The following is a description of a gene set: species: Homo sapiens Human Gene Set: HP_FUNCTIONAL_ABNORMALITY_OF_THE_INNER_EAR Functional abnormality of the inner ear An abnormality of the function of the inner ear., and this is the list of marker genes: OTX2, MAK, BCS1L, STAT4, ERCC6 (NCBI Gene Id 282965), RFT1, LRP5, CDHR1, REST, PNPLA6, NLRP12, COG7, MT-ND4, GRXCR2, MITF, SLC9A1, EDC3, EDN3, MT-CYB, SCN2A, CDC42BPB, ADA2, SLC30A9, HOXA11, SQSTM1, WBP4 (WW domain binding protein 4), KCNAB2, COL4A3, ARSL (NCBI Gene Id 415), CNOT3, RAD21, SIX1 (SIX homeobox 1), SMC3, CALM2, PCARE, PTRH2, CNNM2, IL12A-AS1, SCN1B, SIX3, CRYM, FTO, IDH3B, GSDME, PGAP2, S1PR2, OTOGL, TRDN, FOXRED1, CALM1, ARSG, ALMS1, GABRD (NCBI Gene Id 2563), ARNT2, GJA8, DHDDS, PRPF6, DNAJC19, RFC2 (NCBI Gene Id 5982), MT-ND2, FGF10, C4A (complement C4A (Chido/Rodgers blood group)), IL12A, GUCA1B, ARID1B, MARS2, NDUFAF8, ASCL1, COL25A1, IL12B, IGF1, GJB3, PRPF4, FHL2, XPC, HLA-DPB1, HLA-B, RARA, PTPN22, ATP1A3, PEX10, COA8, CDON, ATP5F1D, NR2E3, GIPC3, RBM8A, CRIPTO, PEX14, NEU1 (neuraminidase 1), MAP3K20, ODC1, NDUFV2, NDE1, DNMT1, ARX, TMEM126B, IDUA, COQ6, CPLX1, TTN, SLC39A7, ACVR1, CYP7B1, RHO, FBXW4, DHX38, GMPPB, ALDH18A1, CEP78, OTOG, RNU12, RFC1, PRDM16, POLD3, DIAPH1, MT-TC, NPM1, PLAA, DSPP, EPRS1, SEM1, TYMP, BCAP31, KCNA5, NKX2-6, POLG, DCAF17, ATP5MK, TPM2, WDR37, POU3F4, FGF3, POMK, PRDM12, RYR1, LRP12, GLA, MYCN, WDR11, STAT5B, TAC3, MRAS, WDR81, BICRA, HOXA2, EBP, SNAP25, VEZF1, TRNT1, TGIF1, LDB3, PRDM5, LRP4, SH2B1, TAFAZZIN, IFT140, FKTN, MPL, VAMP1, BAG3, MRPS7 (NCBI Gene Id 64967), B3GALT6, SLC52A2, SLC17A8 (NCBI Gene Id 64944), BUD23, DBH, KIF7, PEX26, ABHD12, FOXP2, HAAO, BTRC, NEDD4L, CRYAB, MT-TK, RAC1, RIT1, HDAC4, CCR1, KLHL7, NDUFS4, TMEM147, PSEN2, MLX, TRAPPC11, CSRP3, ROBO3, ADK, BDP1, TSPEAR, CEACAM16, MAP2K1, SLC4A11 (solute carrier family 4 member 11), EBF3, TMTC4, NDUFB3, IGBP1, TRAPPC4, GCGR, HGF, CRLS1, PERP, ERCC3, CHCHD10, COX11, IL10, TRRAP, ASAH1, GLI2, TRPM4, KCNH1, HACE1, PMP22, GDF5, SOX6, DNASE1L3, IDS, CLRN2, PRPS1, LRAT, XPA, FH, MT-ND1, GLYCTK, SOS1, ELOVL1, NAA80, ZMPSTE24, NDUFAF5, KIZ, CFAP418, SLC25A4, MINAR2, RPE65, TMEM270, OTOF, SELENOI, TPO, MYH11, MEFV, JAG1, SLC29A3, NDUFAF1, DHX16, TPK1, GPR156, TULP1, ACOX1, PEX5, ABHD5, PJVK, PEX13, RILPL1, PHOX2A, ILDR1, DLL1 (delta like canonical Notch ligand 1), POGZ, SLC25A11, USH2A, TIMM8A, ELMOD3, TMPO, NCF1, AFF4, GATA6, RNF113A (NCBI Gene Id 7737), DIABLO, EP300, PDE6G, HTRA2, PISD, MYH14, PLCH1, EPAS1, TBL1XR1, HS2ST1, RLBP1, NDUFB9, MED12, ACY1, NDUFB11, PIK3R1, CTBP1, SARDH, TBC1D24, RPL10, RBP3, SCN2B, KITLG, SGPL1, NDP, CA4 (carbonic anhydrase 4), FGF17, CNOT1, ERBB2, PLN, COL13A1, GNAS, NSD2, SCN5A (NCBI Gene Id 652341), GJB2, METTL27, FGFR3, GAB1, CDC42, ATP6V1B2, DISP1 (NCBI Gene Id 84976), TAOK1, ITGB3, CLPP, VPS13B, PRKAR1A, ESRP1, NDUFAF2, CDC45, SNAI2, POLD1, MYO7A, MYH6, UQCC2, DSP, LRP2, COX16, PRKDC, GYG1, SDHA, NDUFA6, CALR, G6PC3, MRPS2, FUS, SBF2 (NCBI Gene Id 81846), ZNF699, PPIP5K2, TOPORS, MANF, COL9A3, VPS4A, IMPG1, RP1L1, COCH, DKK1, DNAJC3, TBK1, TRPV3, LORICRIN, MT-TN, CCDC141, PDE6B, WFS1, CAP2, LARS2, STAT3, SCAPER, CHD7, CASZ1, ATPAF2, NEXN, SCN4B, PLS1, CBL, VPS37D, KCNE1, DLST, GET3, CLCN3, CLDN9 (NCBI Gene Id 9080, claudin 9), SIX6, SCD5, MECOM, SMCHD1, DHCR7, ITGA2, PEX16, DMP1, TACR3, GNB1, SNAP29, CCDC50, CNGB1, P2RX2, COL4A5, AGRN, RNF13, DVL1, KCNN3, ABCD1, PRMT7, GAS1, SLC19A2, WAC, ACTG1, MCM2, NDRG1, AHR, SPTBN1, STXBP2, RRAS, MT-ATP6, TECRL, MT-TQ, GATA4, GLIS3, SPRY4, NAXD, GUCY2D, HGSNAT (NCBI Gene Id 8119), SLC1A3, DTYMK (NCBI Gene Id 9102), PORCN (porcupine O-acyltransferase, NCBI Gene Id 65017), PML, NDUFAF4, CRX, TIMMDC1, MARVELD2, TNNT2, TRPV4, SLC26A4, NDUFA11, TBL1Y, P4HA2, KCNJ10, KARS1, HAX1, MT-TI, PNP (purine nucleoside phosphorylase), NOTCH3, GJA5, ATP11A, VCP, RP2, SOST, KDM6A, SETD2, ABCC1, KIAA1549, MLXIPL, PSEN1, EPG5, ABCC9, SLC35A2, LZTR1, EYA1, BCOR, ANKH, SPATA7, SPTSSA, CNBP (NCBI Gene Id 7555), GTF2I, SLC18A3, UBA1, CHD2, DES, ACTB, MT-CO3, IDH3A, TP63, GIPC1, FITM2, FAM149B1, THPO, LETM1, DNMT3B, CREBBP, ARSA, HSD17B4, PTDSS1, OPA1, NIPBL, BSND, ATP6V0A4, DUX4, ARL6, GABRB3, CRKL, TLR4 (NCBI Gene Id 7099), RPGR, GPSM2, CRB1, TPRN, ZIC2, PDE1C, OFD1, PRRT2, NDUFS3 (NCBI Gene Id 4722), NDUFS8, NUP155, ZNF469, FGF8, NEK2, KIAA0586, FEZF1, GRXCR1, ALG12, CLIP2 (NCBI Gene Id 84805), ATP5F1A, MYO9A, ATG7, ERAL1, CARS1, CERKL, HLA-DPA1, FAM161A (NCBI Gene Id 84140), NCAPG2, GTF2H5, MT-TE, SNX14, AIFM1, ABCC6, MT-ND6, ROBO1, TBCK, AP1S1, PEX11B, SCN1A, TK2, MAPK10, VCL, GJA1, SH3TC2, NODAL (nodal growth differentiation factor), MYMK, ATXN3, MAP1B, FGFR2, MEN1, ERCC8, SALL4, IYD, NDUFB10, BAZ1B, IMPG2, ANOS1, SNRNP200, MIR96, ATP5F1E, ASH1L, PRPF31, ATP1A2, HS6ST1, NSMF, IARS2 (NCBI Gene Id 55699), KCNJ2, NABP1, CDK8 (NCBI Gene Id 1024), COL27A1, TUBB3, IRF2BP2, GNRHR, ELN, TNFRSF11B, MOGS, TARDBP, KCNA1, MICOS13, CDH11, KISS1R, KRAS, CLTC (clathrin heavy chain), FOXC1, SUCLA2, EFNB1, CCND1, ELMO2, BRAF, BMP4, SDHC, MT-CO1 (mitochondrially encoded cytochrome c oxidase I), MYO6, PDE6A, INF2, CTNNB1, RDH12, MTSS2, PRPF8, NDUFS7, USH1C, MYO3A, PRPF3, EPOR, FOXH1, PDGFB, MYH7, PCDH15, HOXB1, CDH23, SOS2, ARHGEF18, RNF170, PEX1 (NCBI Gene Id 7788), PPP2R3C, PDK3, SLITRK6, PTPN11, ATP2B2, TOP3A, BEAN1, TBX22, KCNJ5, RRAS2, AP1S2, BEST1, COL4A6, UBR1, IL23R, JUP, DNMT3A, PNPLA2, TMC1, COL9A2, RASA2, SDHAF2, FIBP (NCBI Gene Id 9158), MT-TF, EIF3F, CTLA4, TXNRD2, MRPS28, ACO2, FSCN2, TMEM126A, MPEG1, AIP (aryl hydrocarbon receptor interacting protein), GMPPA, SRPK3, DLX6, GRHL2, RNF220, AARS1, GLI3, TUBA1A, TBL2, CIB2, TG, NDUFAF3, MAN2B1, TMEM127, ZBTB16, MT-TH, MMP23B, VHL, YAP1, SOX2, ATP6AP1, CAT, MYBPC3, GPC4, MT-TL1, PROK2, KCNJ3 (potassium inwardly rectifying channel subfamily J member 3), LRTOMT, SETBP1, GBA2, FAT4, NDUFA1, POU1F1, SPRED2, GGPS1, PHEX, GTF2IRD1, DAB1, MPZ, SLC26A5, PIK3C2A, ATP6V1B1, MYD88, MBTPS2, HESX1, PIGV, JPH2, DNM1, DUSP6, CUX2, SGCD, MPZL2, KCNQ1, NAGA, ERCC5, DIAPH3, GDF6, ROM1, SERAC1, ARHGDIA, GALK1, NDUFS6, LIMK1, TP53, TRMT10C, KCNQ2, SPNS2, USP48, TAF6, SNUPN (NCBI Gene Id 10073), PEX2, RBMX, LMNB1, SH2B3, PHYH, NF1, TWNK, MECR, SRP72, CLCNKA, SMC1A, ESPN, TET2, DCHS1, NOP56, TNNC1, IARS1, FOXI1, TCAP, IFT88, SEMA4A, ENPP1, GTF2IRD2, ERCC4 (NCBI Gene Id 7509), SLC52A3 (solute carrier family 52 member 3), ARL3, NARS2, LMOD2, TARS1, NMNAT1, IFNGR1, TUBB4B, VPS33B (VPS33B late endosome and lysosome associated), BCKDK, FBN1, TPM1, MERTK, CD164, DLX5, DMXL2, GJB1, NDUFV1, SLC5A7, NOG, GJB6, SURF1, MT-ATP8, SYNE4, MT-TW, PCNA, SOX10, MARS1, JAK2, TFAP2A, VSX1, PRKCZ, COX10, SOX3, MVK, NPPA, NUMA1, KCNE2, ATRX, RRM2B, CLIC5, CNGA1 (cyclic nucleotide gated channel subunit alpha 1), PDZD7, NDUFS2, AFG2A, CACNA1A, FXN, CSPP1, HDAC8, NR0B1, MYL2, MPLKIP, CLDN14, PAX3, CACNB4, RRM1, PEX19, RYR2, SDHD (succinate dehydrogenase complex subunit D), COL3A1 (collagen type III alpha 1 chain), AP3D1, ALG11, PITX2, TTR, CC2D2A, FBXW7, PPCS, KLRC4, UBE4B, ERCC2, NKX2-1, KMT2D, UBAC2, EYS, MYO15A, COL11A2 (NCBI Gene Id 494120), SAG, ADAMTSL1, ZFX, ERAP1, RP1, PGM3, FKBP14, FAS, RECQL4, XRCC4, PRORP, TWIST1, SALL1, CDC14A, COL11A1, RAF1, GP1BA, DCDC2, MIA3, MET, PRG4, UNC13D, THRB, MT-ND3, RBM20, ESRRB, RET, AFG2B, MPDZ, CISD2, MAFB, TNNI3, ZNF513, PROP1 (NCBI Gene Id 5626), ACTN2, MT-TV (mitochondrially encoded tRNA-Val (GUN)), SLC12A3, DCC, RAB23, RTTN, SUFU, LUZP1, PEX12, ARL2BP, CASQ2, PHOX2B, FIG4, NLRP3, SPTBN4, FIP1L1, RPL3L, FLI1, SHH, RDX, CACNA1G, RP9, COG5, FKBP6, FLNA, GATA2, PSAP, VPS11, TUB, MT-ND5, LMX1B, CCBE1, SDHB, LONP1, CD109 (CD109 molecule), BRD4, CLCNKB, BBS2, BAG5 (NCBI Gene Id 9529), AP1B1, PTCH1, TAF1A, NEFL, NDUFS1, COQ2, PRCD, OTOA, RPS6KA3, PDGFRB, IMPDH1, POMGNT1 (NCBI Gene Id 55624), GATA5, SMPX, STX1A, C1QBP, MDH2, ANKRD1, MYL4, SPTLC1, NKX2-5, MAF, HSPG2, PEX6, ADPRS, CD151, GRAP, LARS1, SYT2, SPEN, SLC25A1, ALG2, MT-TP, PRF1, PCNT, STIL, KIF1B, ROR1, CHAT, LHX4, MT-CO2, CHN1, PAX2, AAAS, HOXA1, SLC12A2, WNT10B, PEX3, TMEM38B, FAM20C, IFT172, DUOXA2, CALM3, RNASET2, COG4, NEUROG1, ERCC1, GUSB, SLC39A14, KCNJ16, GATA3, RDH5, LOXHD1, RIPOR2, ZIC1, SUMF1, RERE, ADGRV1, TDO2, PUS7, AMMECR1, ITGA2B, BBS1, DNAJC30, CDK5RAP2, ZEB2, RPS28, MYH9, SEMA3A, TRIOBP, CEP250, CHSY1, MT-RNR1, GJC2 (NCBI Gene Id 57165), FRG1, PNPT1, REEP6, TTC8, GP1BB, EIF4H, IL17RD, DUX4L1 (NCBI Gene Id 22947), BTD, ADCY1, COL9A1, BTK, HAND2, FGF14, DDB2, USH1G (USH1 protein network component sans), CASK, ZNF408, OSBPL2, STAG2, PUS3, MAX, NUBPL, TNFRSF1A, STX11, AHI1, SIN3A, LMNA, HLA-DRB1, KISS1, GTF2E2, ELAC2, MT-TS2, GREB1L, NF2, CATSPER2, EYA4, ABCA4, STRC, PTPRQ, IRX5, COL2A1 (collagen type II alpha 1 chain), MGAT2, BCR, SF3B2, TYR, AGBL5, NOTCH2NLC (notch 2 N-terminal like C), PKHD1L1, GNPTAB, TRMT10A, SKI, GFER, PPP1R15B, GALE, SLC7A14, SIX5, SGMS2, DGUOK, LHX3, TMEM67, XPNPEP3, DNM1L, MFN2, FLRT3, DUOX2, NRL, GBA1, LIG3, XYLT2, TMEM132E, FGFR1, GATAD1, MAP3K7, GNRH1, GAS2 (NCBI Gene Id 2620), THOC2, SLC44A4 (solute carrier family 44 member 4), TANGO2, TUBB2B, KIF21A (kinesin family member 21A), HSD17B10, STX4, MEGF8, SUCLG1, THOC1, NDNF, MEOX1, GCDH, MYPN, DSG2, PAX1, ACTC1, FLNB, HNRNPK, KYNU, PDPN, LAMA4, YARS1, SCN3B, LHFPL5, HARS2, PRPH2, HARS1, PEX7, DOLK, RGR, PROM1, PLOD3, HOMER2, CLRN1, TNC, PROKR2, TMPRSS3, MAPK1, FGFRL1, EPS15L1, WHRN, DMD, TECTA, PRTN3, NRAS, EDNRB, SLC5A5, FOXL1 (NCBI Gene Id 2300), NHLH2